The following is a description of a gene set: Pathway Definition from KEGG: FN1 -> (ITGA+ITGB) -> RHOG -> (DOCK1+ELMO) -> RAC Human Gene Set: KEGG_MEDICUS_REFERENCE_ITGA_B_RHOG_RAC_SIGNALING_PATHWAY ITGA/B-RHOG-RAC signaling pathway. Pathway ID: N00951. Pathway type: Reference. Pathway class: nt06135 Cytoskeletal regulation (viruses and bacteria). species: Homo sapiens, and this is the list of marker genes: ITGB6 (NCBI Gene Id 3694), RAC1, ITGB7, ITGA10, ITGA8, FN1, RAC3, ITGA2B, ELMO3, ITGB5, ITGB8, ITGA2, ELMO2, ITGA5, ITGA11, ITGAV, ITGA9, ITGA3, ITGB4 (integrin subunit beta 4), RHOG, DOCK1, ELMO1, RAC2, ITGB1, ITGA7, ITGA4, ITGA1, ITGB3